Given this list of marker genes ABCA8, ATP2A2, ATP6V1G1, ABCC10, TMEM94, ABCB1, ATP1A1, ABCC6, ABCB4, ATP13A5, ABCB6, ABCD2, ABCG8, ATP5F1B, ABCC1, ATP12A (ATPase H+/K+ transporting non-gastric alpha2 subunit), ABCB8, ABCG5, ABCA5, ABCD1, ATP6V1H, ATP6V0A2, ABCA9, ATP6V1C1, ATP8A1, ATP13A1, ABCC3, ATP2A3, RALBP1, ATP6V0E1, ATP1A2, ABCA7, ABCB10, ATP6V1D, ATP1A3, TOMM20, ABCG2, ATP6V0D1, ATP6V1A, KCNJ11, ATP6V1B1 (ATPase H+ transporting V1 subunit B1), ABCB5, ATP6V0A1, TCIRG1, ATP2C1, ATP1A4, ATP2B1, ATP7A, ATP2B2, ATP13A2, ATP6V1G2, ABCA1, ATP13A4, ATP4A, ABCA10, ABCA6, ABCA3, ABCC9, ABCC12, ABCA2, ABCC4, ABCD3, ATP6V0D2, ABCA12, ATP13A3, ABCC8, ATP7B, ATP2B3, ATP6V1F, ABCC5, ABCC2, ATP6V1E2, SLC36A1, TAP2, ATP6V1E1, ABCD4, ABCA13, ATP6V0E2, ATP1B1, ATP6V0B, ATP4B, ATP6V1B2, ABCC11, ABCG1, ATP2B4, ABCB9, CFTR, ATP6V0C, KCNJ8, ABCB7, ABCB11, ATP2C2, ABCG4, ATP6V1G3, ATP6V1C2, ABCA4, ATP6V0A4, TAP1, ATP2A1, here is a description of the gene set: Primary active transporter of a solute across a membrane, via the reaction: ATP + H2O = ADP + phosphate, to directly drive the transport of a substance across a membrane. The transport protein may be transiently phosphorylated (P-type transporters), or not (ABC-type transporters and other families of transporters). Primary active transport occurs up the solute's concentration gradient and is driven by a primary energy source. studied in species Homo sapiens Human Gene Set: GOMF_ATPASE_COUPLED_TRANSMEMBRANE_TRANSPORTER_ACTIVITY